Given this list of marker genes SMAD4, FOXE3, HLA-DRB1, MYLK, HLA-B, PRKG1, ELN, TGFB3, PTPN22, SMAD2, ACTA2, HEY2, P4HA2, TGFBR2, MYH11, THSD4, LOX, MFAP5, NSMCE2, TGFBR1, FBN1, MAT2A, SMAD3, TGFB2, here is a description of the gene set: Abdominal aortic aneurysm species: Homo sapiens Human Gene Set: HP_ABDOMINAL_AORTIC_ANEURYSM An abnormal localized widening (dilatation) of the abdominal aorta.